The following is a description of a gene set: Genes having at least one occurrence of the motif CTBATTTCARAAW in the regions spanning 4 kb centered on their transcription starting sites. This matches the CEBPG transcription factor binding site V$CEBPGAMMA_Q6 (v7.4 TRANSFAC). Human Gene Set: CEBPGAMMA_Q6 studied in species Homo sapiens, and this is the list of marker genes: PDZK1, STC1, HSD11B1, LSAMP, PDZRN4, E2F8, ZSCAN29, LBX2-AS1, NCKAP1L, SERPINB2, BCAS1, JARID2, IL10, NDST2, ELAVL2, SCAMP3, NCALD, CXCL9, ITGB3BP, CASZ1, SEMA6A, TUT1, SSH2 (slingshot protein phosphatase 2), EGFL6, EYA1, PABPC1, WTAP, ID4, PRUNE2, GABRA1, HOXA4, SYT16, B4GALT2 (beta-1,4-galactosyltransferase 2), PPP4R3C, CRACDL, TASOR, HOXA9, USP5, CTNNAL1, PACSIN3, MITF, NSRP1, ALDH1A2, SOAT1, PDS5A, PPARGC1A, LMO3, NRP2 (NCBI Gene Id 8828), PHYKPL, SPAG9, HS3ST5, IMPDH1, CDKN1B, SST, MGLL, ADAMTSL2, SLC39A13, ARHGAP30, ALB, PSMA1, GPLD1, LUC7L3, ST18, CTBP2, TRIM8, KIT, RALGDS, LEAP2, GRIN2B, NRAS, OR9A4, GSTO2, MYH2, LHX6, NEDD4, WBP4, GNPNAT1, C1orf122, SLC38A1, WWP1, SCP2D1, FES, MNAT1, CNTLN, SLITRK2, CASC2, TCEAL8, DRG1 (NCBI Gene Id 4733), HABP2, GPR18, SALL1, CSNK2A2, DMP1, MOAP1, SELENOF, CDC42EP3, UGDH, RPLP0, PDGFRA, BRAF, PYM1, HS2ST1, PLBD1, FAM53B, PPARG, ZNF547, PTCHD4, H3-3B (NCBI Gene Id 3021), NPM3 (nucleophosmin/nucleoplasmin 3), PAQR9, LRR1, RTL3, UNC13B, UXT, BHLHE22, HESX1, KCNA1, MID1, ACTN3, PCDH18, FAM83H, TAC4, TRERF1, ARL4C, SCG2, SLC6A5, NR6A1, CDK6, DAAM1, ZNF516-DT, CAPS (calcyphosine), KCNQ5, SLIRP, CRLF3, VXN, HOXB3, NSD3, PURA, YWHAG, NOVA1, HTRA4, SP6, PRKAG1, FZD4, PLA2G4D (NCBI Gene Id 283748), ZBTB20, PTK2, DDAH2, SALL3, CELF2, SKIDA1, DLG2, ENTPD1, FOXP2, DGKA, ACSL4, SP8, PPFIA2, OIT3, HOXB2, KCNF1, NR2F1, TCEA3, NF1 (neurofibromin 1), IL3, PPP1R8, OSBPL9, ADARB2, CREB5, KLF7, GNAQ, KCNJ13, RCOR2, CDK11B (NCBI Gene Id 984), GPBP1, SRP68, RASGRP3, EIF5, FLI1, MYO18A, PRDM1, SMARCE1, SOBP, PPP1R12B, PTH2R, UBE2K, RORB, CAMK2G, YRDC, RBM18, PPP3CB, NPR3, ATL2, CYCS, FZD2, SPATA18, CSF2, SOX14, GPR22, DLX1, ZNF503, CSNK1G3, FARP1, COL3A1, ALKBH1, CHRNA6, CHD5, ZBTB32, LINC00525, DHX40, TTL, PRDM13, UNC13D, TFAP2D, ADPGK, G0S2, MARS1, HOXA3, SLC10A7, POU5F1, NTRK2, ANKS1B (ankyrin repeat and sterile alpha motif domain containing 1B), PTPRG, OPALIN, CDKL5, KIF2B, RUNX1T1, PTK7 (NCBI Gene Id 5754), TRAF3IP3, WDR64, CDK11A, NIPBL, SEPHS1, PRRT2, JMJD1C, MEF2C, RTL9, HNF4G, ZDHHC24, SERTAD4, LMO4, NAV3, MRRF (NCBI Gene Id 92399), CPNE1, SHISA6, PAK1IP1, LDB2, ELOA2, NSD1, TBX6, RFX8, METAP2, AAK1, FOXN3, MN1, PROKR2, CTNNBL1 (catenin beta like 1), TMPO, CDCA3